The following is a description of a gene set: Human Gene Set: GOBP_RESPONSE_TO_HEAT studied in species Homo sapiens Any process that results in a change in state or activity of a cell or an organism (in terms of movement, secretion, enzyme production, gene expression, etc.) as a result of a heat stimulus, a temperature stimulus above the optimal temperature for that organism., and this is the list of marker genes: CASQ1, MAPT, GSK3B, DNAJB1, SOD1, EIF2S1, ATXN3, TP53INP1, MTOR, HDAC2, RBBP7, HSBP1L1, TRPM2 (NCBI Gene Id 7226), DNAJA2 (NCBI Gene Id 9237), HSP90AB3P, EIF2B4, HSP90AA2P, PSIP1, LYN, SUMO1, DNAJA4, EIF2B5 (eukaryotic translation initiation factor 2B subunit epsilon), HSP90AA1, TRPV4, ANO1, HDAC6, HSBP1, HSP90AB1, HSPA1B, IER5, HSPB1, MICA, ATR, ST8SIA1, HSP90AB4P, STAC (NCBI Gene Id 6769), HSPB2, EP300, MAP2K7, SCARA5, DNAJA1, AKT1 (AKT serine/threonine kinase 1), TRPA1, IGF1, NOS1, MAPKAPK2, DAXX, CETN1, HTRA2, EEF1D, DNAJB4, ASIC3, PIRT, FGF1, HSPA2, DNAJC7, BAG3, CREBBP, IRAK1, NOS3, ATM (ATM serine/threonine kinase), STUB1, P2RX3, CRNN, HSPB6, SCN2B, CRYAB, HSPA1A, HSP90AB2P, SLC52A3, GCLC, YWHAE, DNAJA3, SCN11A, EIF2B2, TRPV1, HPCAL4, CHORDC1, EIF2B3, PRKACA, DNAJC2, TCIM, SLU7, HIKESHI, NF1, EIF2B1, PDCD6, VCP, DHX36, LRP11, THBS1, IL1A, HSPA6, SIRT1, DNAJB6, ZFAND1, HSF1, CRYAA, CLPB, MICB, HMOX1, TPR, CXCL10, TFEC